The following is a description of a gene set: species: Homo sapiens The gene expression program underlying the specification of human cell types is of fundamental interest. The study authors generated human cell atlases of gene expression and chromatin accessibility in fetal tissues. For gene expression, the study authors applied three-level combinatorial indexing to >110 samples representing 15 organs, ultimately profiling ~4 million single cells. The study authors leveraged the literature and other atlases to identify and annotate hundreds of cell types and subtypes, both within and across tissues. Our analyses focused on organ-specific specializations of broadly distributed cell types (such as blood, endothelial, and epithelial), sites of fetal erythropoiesis (which notably included the adrenal gland), and integration with mouse developmental atlases (such as conserved specification of blood cells). These data represent a rich resource for the exploration of in vivo human gene expression in diverse tissues and cell types. Human Gene Set: DESCARTES_FETAL_STOMACH_ENS_NEURONS from publication Cao J, O'Day DR, Pliner HA, Kingsley PD, Deng M, Daza RM, Zager MA, Aldinger KA, Blecher-Gonen R, Zhang F, Spielmann M, Palis J, Doherty D, Steemers FJ, Glass IA, Trapnell C, Shendure J (PMID 33184181) Marker genes curated from the annotated cluster as represented in the Descartes Human Gene Expression During Development database., and this is the list of marker genes: SCN11A, MAP6, PCDH15, STMN2, NKAIN1, TCEAL5, ACTL6B, TMEM255A, TUBB2A, ZNF77, SYT5, DPP6, UNC5C, CELF5, CTNNA2 (catenin alpha 2), SEZ6L, OLFM3, LHFPL3, PLD5, GAP43, KLF3-AS1, PTPRR, CNTNAP2, LINC02641, WDR5B, RGS11, ANKRD29, SLC5A7, LRFN2, PCBP3, NOS1 (nitric oxide synthase 1), STAC, NPY, KCNQ3, INA, CUX2, EML5, FAM163A, ATP1A3, TUBB2B, HOXB5, NDRG4, ARPP21, SHF, MTCL3, OLFM1, PRPH, FHOD3, KCNIP4, ELAVL3, CNTN5, SYN2, UCHL1, NPTXR, ADCYAP1R1, ATCAY, MAPT, SYT1, HCN1, MIR137HG, LINC02198, PHOX2B-AS1, DSCAM, CNGB1, SPOCK1, FSTL5, LINC01695, MYT1L, SHROOM1 (NCBI Gene Id 134549), DCX, EEF1A2, CHRNA3, ELAVL4, NWD2